Given this list of marker genes TCF7L2, CTNNBIP1, AXIN1, STRN3, LEF1, STRN, STRN4, CNOT1 (NCBI Gene Id 51579), here is a description of the gene set: Binding to an armadillo repeat domain, an approximately 40 amino acid long tandemly repeated sequence motif first identified in the Drosophila segment polarity protein armadillo. Arm-repeat proteins are involved in various processes, including intracellular signaling and cytoskeletal regulation. Human Gene Set: GOMF_ARMADILLO_REPEAT_DOMAIN_BINDING species: Homo sapiens